The following is a description of a gene set: species: Homo sapiens Human Gene Set: LOPEZ_TRANSLATION_VIA_FN1_SIGNALING Genes translationally up-regulated in HUVEC cells (endothelium) grown on FN1 compared to those grown on laminin 1. Integrin signaling promotes, through p21-activated kinase, phosphorylation and inactivation of the tumor suppressor merlin, thus removing a block to mitogenesis in normal cells. However, the biochemical function of merlin and the effector pathways critical for the pathogenesis of malignant mesothelioma and other NF2-related malignancies are not known. We report that integrin-specific signaling promotes activation of mTORC1 and cap-dependent mRNA translation. Depletion of merlin rescues mTORC1 signaling in cells deprived of anchorage to a permissive extracellular matrix, suggesting that integrin signaling controls mTORC1 through inactivation of merlin. This signaling pathway controls translation of the cyclin D1 mRNA and, thereby, cell cycle progression. In addition, it promotes cell survival. Analysis of a panel of malignant mesothelioma cell lines reveals a strong correlation between loss of merlin and activation of mTORC1. Merlin-negative lines are sensitive to the growth-inhibitory effect of rapamycin, and the expression of recombinant merlin renders them partially resistant to rapamycin. Conversely, depletion of merlin restores rapamycin sensitivity in merlin-positive lines. These results indicate that integrin-mediated adhesion promotes mTORC1 signaling through the inactivation of merlin. Furthermore, they reveal that merlin-negative mesotheliomas display unregulated mTORC1 signaling and are sensitive to rapamycin, thus providing a preclinical rationale for prospective, biomarker-driven clinical studies of mTORC1 inhibitors in these tumors. from publication López-Lago MA, Okada T, Murillo MM, Socci N, Giancotti FG (PMID 19451229), and this is the list of marker genes: SRPRA, ARHGDIA, SOCS2, RANBP10, STX16, MCL1, ILF3, EIF3D, THBS1, ANP32A, MMP16, HOXB7, SOX4, TNPO3, PTBP1, PPP5C, SH3GLB2, SRPK2, SSTR2, DAPK3, DYRK1A, RALBP1, SNRPD1, CALD1, GTF2F1, PTMA, EFNB2, HOMER3, RBM25, TGFBR2, TRIO, EIF5B, ZFP36L2, IMP3, PDE3A